Given this list of marker genes ATP6V0E1, ORM1, DIO2, MXD4, H1-2, CXCL6, CCN2, BAIAP2, ASPRV1, CNOT7, NFATC2, DDAH2, ADSS1, FGFR1, GSDME, ATP6V1D, SLC25A4, ADAM8, LXN, SPRR2A, CFTR, CXCL14, HTRA1, CTTN, ANXA1, PCLAF, GRB10, AGXT, FCER1A, SPP1, SLC66A2, SLC20A1, MSMO1, GAP43, DEGS1, ANKH, TSEN15, IGF1 (NCBI Gene Id 3479), CAVIN3, SQLE, SFT2D1, SSR1, TRAPPC12, ANXA2, RPS10, TCEAL9, ADK, TYMS, MPP1, LAT2, IGFBP4, RCAN1, SESN1, RAMAC, SELENOK, PSMD8, JARID2, SLC44A1, GPR162, OLA1, MMP12, TRIM47, ARL8B, MRC1, PPIC, GLB1, SPSB1, CLEC4A, CDC20, CYP51A1, C15orf39, DNAAF10, NOP2, USP4, C3AR1, MFGE8, QRICH1, TAC1, NCAM1, WSB2, FRMD6, OST4, NR2F6, CNN2, PDLIM1, RAB34, CKS2, IL1R1, ZMYM4, BCL2L11, S100A6, HGSNAT, SCGB1A1, MAP6, EFNB2 (ephrin B2), FKBP10, DGKA, PHF1, TMEM176A, CXCL2, PTER, SUCLG2, RARRES2, ANGPT2, LSS, PPP2R1B, SPCS2, EMP1, SNX17, FSTL3 (follistatin like 3), ALAD, NEDD4, FABP5, CDKN1C, COPRS, TMEM109, PTGIS, PDGFRA, MRPS31, RNF13, ITSN1, ARPC5L (actin related protein 2/3 complex subunit 5 like), PRNP, HSPB1, DNMT3A, FGGY, HTR2B, COX7A2, WASHC2A, GAS1, FOSL2, RAB4A, MMP9, METTL3, PRR5, PRDX4, SPHK2, TOP2A, GSTM3, SERPINH1, PAK3 (NCBI Gene Id 5063), CD5L, CDK18, CD28, EPHX1, SLC46A1, LPIN1 (NCBI Gene Id 23175), LGALS1, ARG1 (NCBI Gene Id 383), AOC3, VCL, ITM2A, DNM1, TAGLN, CDK14, CTPS1, RPL23A, MFSD14A, LGMN, MAGED1, ADCY8, ANXA5, EMID1, RNH1, GALC, MYC, ABCC3, IDO1, ATP6V0C, CD83, JUN, RGS10, MMP8, CTSD, SPTSSA (serine palmitoyltransferase small subunit A), NPY, SLC6A8, GJA1, HFE, TTC3, GOLGA7, NAT1, SCOC, DCN, RSU1, S100A4, CA3, ATP6V1A, SYNGR1, GSTM5, CD53, APOE, S1PR1, GAS6, EVI2A, CLU, MAFB, CKB, STMN1, TMEM199, here is a description of the gene set: from publication Szatmari I, Pap A, Rühl R, Ma JX, Illarionov PA, Besra GS, Rajnavolgyi E, Dezso B, Nagy L (PMID 16982809) Human Gene Set: GSE5679_CTRL_VS_PPARG_LIGAND_ROSIGLITAZONE_AND_RARA_AGONIST_AM580_TREATED_DC_DN species: Homo sapiens Genes down-regulated in monocyte-derived dendritic cells: untreated versus rosiglitazone and AM580. Our data indicated that activation of the PPARg nuclear receptor induces a retinoid response in human dendritic cells. In order to assess the contribution of retinoid signaling to the PPARg response we decided to use a combination of pharmacological activators and inhibitors of these pathways. Cells were treated with the synthetic PPARg ligand rosiglitazone (RSG), or with RSG along with the RARa antagonist (AGN193109) to block RARa mediated gene expression, or the RARa specific agonists (AM580) alone. This design allows one to determine if retinoid signaling is a downstream event of PPARg activation and what portion of PPARg regulated genes are regulated via induced retinoid signaling.